Given this list of marker genes CXCR4, DUSP4 (dual specificity phosphatase 4), FPR1, DUSP2, FGF2, GADD45G, FGFR1, DUSP8, C5, RGS4, DUSP6, C5AR1, RGS3, here is a description of the gene set: studied in species Homo sapiens Growth suppressors. Human Gene Set: MODULE_407